Given this list of marker genes H2-DMb1, Unc93b1, H2-DMb2, Fcgr2b, H2-Ab1, Ifi30, Fcer1g, H2-Oa, H2-Aa, H2-Eb2, Traf6, Lgmn, Ctss, Ctse, Cd74, H2-DMa, Pikfyve, H2-Ob, H2-Eb1, B2m, H2-Ea, here is a description of the gene set: Mouse Gene Set: GOBP_ANTIGEN_PROCESSING_AND_PRESENTATION_OF_EXOGENOUS_PEPTIDE_ANTIGEN_VIA_MHC_CLASS_II species: Mus musculus The process in which an antigen-presenting cell expresses a peptide antigen of exogenous origin on its cell surface in association with an MHC class II protein complex. The peptide antigen is typically, but not always, processed from a whole protein.